Given this list of marker genes PIK3R1, GRB2, SOS1, SH2B3, PLCG2 (phospholipase C gamma 2), BTK, GAB1 (GRB2 associated binding protein 1, NCBI Gene Id 2549), EPOR, CRKL, PTPN11, VAV2, BCL2, TRPC6 (transient receptor potential cation channel subfamily C member 6), RAPGEF1, RAP1A, IRS2, CBL, PTPN6, PLCG1, NFKB1, LYN, SHC1, STAT1, TEC, EPO (erythropoietin), STAT5B, MAPK14, JAK2, HRAS, SOCS3, MAPK8 (NCBI Gene Id 5599), BCL2L1, STAT5A, here is a description of the gene set: from publication Schaefer CF, Anthony K, Krupa S, Buchoff J, Day M, Hannay T, Buetow KH (PMID 18832364) Human Gene Set: PID_EPO_PATHWAY EPO signaling pathway species: Homo sapiens